The following is a description of a gene set: species: Homo sapiens Genes having at least one occurrence of the motif CAGTTTCWCTTTYCC in the regions spanning 4 kb centered on their transcription starting sites. This matches the STAT1, STAT2 transcription factor binding site V$ISRE_01 (v7.4 TRANSFAC). Human Gene Set: ISRE_01, and this is the list of marker genes: CRACR2B, DGKA, TSKU, KCNIP3, MOV10, TIFA, TLR7, HTR2C, LMO1 (NCBI Gene Id 4004), EPN1, BATF2, PCDH7, PGK1 (NCBI Gene Id 5230), KRTAP8-1 (NCBI Gene Id 337879), SIK3 (SIK family kinase 3), PIGV, EYA4, PIGR, FAM117A, ERBB2, LCOR, ST3GAL4, MIA2, RANGAP1, FBXO11, USF1, OTX1, OSM, ISOC2, LRP2, RIPK2, ASPA, ADAM15, BCL11A, PARP9, PPP2R5C, PSMA5, TMEM108, EGR2, ANAPC1, OPTN, IFIH1, DTX3L, PPARGC1A, CELF3, IFNB1, SLC25A28, ETV6, PML, KCNN3, AMMECR1, PSMA3, UBA7, LURAP1L, IRF2, OVOL1, LY86, NPR3, EGFL6, FIGN, ANGPTL4, BBX (NCBI Gene Id 56987), C12orf42, VXN, BST2, ETNK1, THBS1, NECAP2 (NECAP endocytosis associated 2), PIK3R3, IL27, UNC5C, CCDC6, CAVIN2, GPR55, BDNF, CD151, GPX1, GPR18, FYCO1 (NCBI Gene Id 79687), MYB, AMER1, SLA, STAT6, PCDHGC3, ZEB2, MAP2K6, ZER1, HEPACAM, RRBP1, KCNJ16, GSDMD, DUSP10, TCF15, TCIRG1, MET, PAX2, PURA, HEPH, CXCL10, RTP4, SH2B3, TBX21, OSBP, FGF9 (fibroblast growth factor 9), DNAH6, ZBP1, SLC12A7, CRK, RTL3, SEMA6D, BTAF1, GPR65, GATA6, SSBP2, NABP2, RBM39, JARID2, MED13, ARMCX6, TNFRSF17, TSC22D2, TCF7L2, ETV5, TNFSF13B, ATP13A1, EREG, TRIM21, CBX4, HLA-F, RAD51AP1, MAP3K11, MEIS1, TMEM59L, ZNF385A, IFNL2, ZBTB7A, ADD3, PCGF5, PLAG1, NUFIP2, CXXC4, IL4, DEPDC7, CDH3, HDAC4, CDK6, TNFSF15, IFI44, SIX1, CDKN2C, ESR1, IL22RA1, CYB5B, CREBZF, CXCL11, AGXT2, WNT8B, MAP2, PARP8 (NCBI Gene Id 79668), PROK2, PTCH1, SERHL, IKZF2 (IKAROS family zinc finger 2), HPCAL1, TAPBP, PRKACA, RIGI, RIMOC1, MS4A1, NT5C3A, ARPP21, DDX60, BLNK, ZNF296, ZFPM1, NKX2-2, CXXC5, KDM4A, SH3BGRL, E2F3, ST8SIA2, NPVF, ERG, CHKA, IL1RAPL1, SORBS1, MSX1, KY, LSP1, FERRY3, KYNU, H1-2 (NCBI Gene Id 3006), COL12A1, MACC1, XAF1 (XIAP associated factor 1), TOP1, PRDM12, LRATD2, APOOL, EPSTI1, EXOC6, GPHB5, TECR, RBPJ, CA10, GNB4, MEF2C (NCBI Gene Id 4208), CRY1, IFIT2, USP44, ARHGEF6, SCRT2, KPNA3, CXCR4, PRKD2, KCNE4, SCN2A, NPNT, DHX58, SLC11A2, RBCK1 (NCBI Gene Id 10616), YWHAG, IKZF3, DAPP1, GRIPAP1, FSBP, KLF14, PRDM16, ISG15, NUB1, AKAP6, ERC1, USP18, PLXNC1, HOMER1, IRF9, EHD4, CACNA2D2, ATXN7L1, HLA-C, TASL (NCBI Gene Id 80231), B2M, PYM1, AIF1, SLC24A1, IFNL3, PITX3, LINC01138, PKN2, IFIT3, MMP25, HMCN1, FMR1